Given this list of marker genes SAR1B, SEC23B, SEC31A, SAR1A, SEC24D, SEC24C (NCBI Gene Id 9632), SEC24A, SEC23A, SEC24B, SEC13, SEC31B, PREB, here is a description of the gene set: Pathway Definition from KEGG: SEC12 -> SAR1 == (SEC23+SEC24) == (SEC13+SEC31) Human Gene Set: KEGG_MEDICUS_REFERENCE_COPII_VESICLE_FORMATION studied in species Homo sapiens COPII vesicle formation. Pathway ID: N01289. Pathway type: Reference. Pathway class: nt06125 Membrane trafficking (bacteria).